The following is a description of a gene set: studied in species Homo sapiens Any process that decreases the rate, frequency or extent of low-density lipoprotein particle clearance. Low-density lipoprotein particle clearance is the process in which a low-density lipoprotein particle is removed from the blood via receptor-mediated endocytosis and its constituent parts degraded. Human Gene Set: GOBP_NEGATIVE_REGULATION_OF_LOW_DENSITY_LIPOPROTEIN_PARTICLE_CLEARANCE, and this is the list of marker genes: LDLR, MIR17, KHSRP, MIR27B, MIR133A1, MIR185, MIR199A1, IL19, MYLIP, MIR148A, ITGAV, ABCC8, ITGB3, APOC3, PCSK9, CSK, MIR27A